Given this list of marker genes EDN1, LAMA2, STAT4, IL2RA, PLCB4, IDS (iduronate 2-sulfatase), COL5A1, VPS13A, ZMPSTE24, IL2RB, ANKRD55, PTPN2, COL5A2, COL1A1, CD247, PTPN22, LMNA, GNAI3, SF3B4, here is a description of the gene set: species: Homo sapiens Abnormality of the temporomandibular joint An anomaly of the temporomandibular joint. Human Gene Set: HP_ABNORMALITY_OF_THE_TEMPOROMANDIBULAR_JOINT